Given this list of marker genes Fcer1g, Timp3, Clu, Edn1, Fth1, H2-K1, Gpx3, Prss23, Ifi27l2a, Mgst1 (NCBI Gene Id 66600), H2-Ab1, Sod3, Ndrg1, H2-D1 (histocompatibility 2, D region locus 1), Zfp704, Ly6a (NCBI Gene Id 17065), Cd74, Ssb, Ctsd, Kap, Jam2, Cgnl1, H2-Aa, Plac9, H2-Eb1, here is a description of the gene set: from publication Tabula Muris Consortium (PMID 32669714) studied in species Mus musculus Mouse Gene Set: TABULA_MURIS_SENIS_KIDNEY_KIDNEY_MESANGIAL_CELL_AGEING